Given this list of marker genes SPOUT1, DLGAP5, ABRAXAS2, TBCCD1, TMEM201, NUMA1, BNIP2, CEP250, EMD (NCBI Gene Id 2010), AURKA, NUBP2, MISP, NPM1, UBXN2B, NDE1, here is a description of the gene set: studied in species Homo sapiens A centrosome from which one pole of a mitotic or meiotic spindle is organized. Human Gene Set: GOCC_SPINDLE_POLE_CENTROSOME